Given this list of marker genes SLC35D2, GPC6, GPC3, SDC1, HS6ST2 (heparan sulfate 6-O-sulfotransferase 2), SDC3, NDST3, NDST1, GPC4, EXT2, EXT1, HSPG2, SDC2, HS3ST2, GPC1, HS3ST1, SDC4, GPC2, AGRN, NDST2, GPC5, HS6ST1, HS3ST3A1, HS6ST3, HS3ST3B1, HS3ST5, HS2ST1, NDST4, HS3ST6, HS3ST4, GLCE, here is a description of the gene set: HS-GAG biosynthesis Human Gene Set: REACTOME_HS_GAG_BIOSYNTHESIS studied in species Homo sapiens